The following is a description of a gene set: Human Gene Set: GOMF_NERVE_GROWTH_FACTOR_RECEPTOR_BINDING Binding to a nerve growth factor receptor. studied in species Homo sapiens, and this is the list of marker genes: NTF3, BEX3, BDNF, NGF, NTF4